The following is a description of a gene set: species: Homo sapiens Enables the transfer of L-glutamine from one side of a membrane to the other. L-glutamine is 2-amino-4-carbamoylbutanoic acid. Human Gene Set: GOMF_L_GLUTAMINE_TRANSMEMBRANE_TRANSPORTER_ACTIVITY, and this is the list of marker genes: SLC38A1, SLC1A4, SLC38A9, SLC38A3, SLC38A7, SLC38A5, SLC38A2, SLC38A6, SLC1A5